The following is a description of a gene set: This event has been computationally inferred from an event that has been demonstrated in another species.<p>The inference is based on the homology mapping from PANTHER. Briefly, reactions for which all involved PhysicalEntities (in input, output and catalyst) have a mapped orthologue/paralogue (for complexes at least 75% of components must have a mapping) are inferred to the other species. electronically inferred by orthology from the curated human pathway part of: Signaling by PTK6 studied in species Mus musculus Reactome Pathway: PTK6 Down-Regulation, and this is the list of marker genes: Ptpn1